Given this list of marker genes MXI1, SRSF2, CBFA2T3 (CBFA2/RUNX1 partner transcriptional co-repressor 3), DGKG, RUNX1, FOXO4, RAB31, EMP3, N4BP2L1, MTSS1, TLR1, CDKN2D, FGL2, SCRN1 (secernin 1), SAP18, RAB6A, SNU13, SUN1, DENND4B, CPT1B, EFR3A, CTDSP2, CAPZA2, ING1, NPC2, TUBA1A, PLAGL1, CACNA1A, ID3, EGR3, BMI1, YIF1A, NCF4, ZBTB20, GABBR1, BCL6, CLIC4, DUSP7, SPEN, HNRNPA3 (heterogeneous nuclear ribonucleoprotein A3), NPTN, JAK2, HLA-F, MNT, TBL1X, PIP5K1B, ARFRP1, RHOC, here is a description of the gene set: studied in species Homo sapiens The usage of the immunoglobulin (Ig) V(H)3-21 gene is associated with poor prognosis in B-cell chronic lymphocytic leukemia (B-CLL) despite V(H) gene mutation status. Many V(H)3-21+ patients also display restricted heavy- and light-chain Ig gene rearrangements, implying a role of antigen selection in disease development. To explore the specific phenotypic/genotypic features among V(H)3-21+ B-CLLs, we compared gene expression patterns in 15 V(H)3-21+ and 24 non-V(H)3-21 patients (11 with unmutated and 13 with mutated V(H) genes) using Affymetrix microarray analysis (approximately genes). A distinct expression profile was identified for V(H)3-21+ patients in contrast to the Ig-unmutated and -mutated groups. By applying different algorithms, the data enabled an efficient class discrimination of the V(H)3-21+ subset based on 27 or genes. A set of genes was sorted out which, using different analytical methods, consistently gave a distinction between V(H)3-21+ and non-V(H)3-21 samples. Several of these genes are involved in regulation of DNA replication/cell-cycle control, transcription and protein kinase activity, which may render the V(H)3-21+ cells with a higher proliferative drive. However, no clear evidence of increased B-cell receptor signaling was found in the V(H)3-21+ group. Altogether, our identification of a specific V(H)3-21 profile may provide insights into the pathogenesis of the V(H)3-21+ subgroup. Human Gene Set: FAELT_B_CLL_WITH_VH_REARRANGEMENTS_UP from publication Fält S, Merup M, Tobin G, Thunberg U, Gahrton G, Rosenquist R, Wennborg A (PMID 15817677) Genes up-regulated in B-CLL (B-cell chronic lymphocytic leukemia) patients with mutated immunoglobulin variable heavy chain (VH) genes.